The following is a description of a gene set: Genes predicted to be targets of miRBase v22 microRNA mmu_miR_5121 in miRDB v6.0 with MirTarget v4 prediction scores > 80 (high confidence targets). Mouse Gene Set: MIR_5121 studied in species Mus musculus from publication Chen Y, Wang X (PMID 31504780), and this is the list of marker genes: Apbb2, Mal, Lrrtm2, Foxp4, Cxcl14, Abhd14a, Nfia, Trp53inp1, Disp3 (dispatched RND transporter family member 3), Eno2, Dbndd1, Tmem150c, Gabarapl1, Adgrf2, Mtfr1, Senp1, Kmt5b, Arpp21, Fgf14, Jade2, Tmem144, Cpeb2, Dlx4 (distal-less homeobox 4), Farp1, F2rl1, Jdp2, Glce, Fat3, Rgs18, Moxd1, Neurod1, Zfp236, Zfp94, Kansl1l, Canx, Lrrtm4, Arnt2, Tram1, Nacc1, Stmn2, Adamts12, Nsd3, Zfhx4, Gorab, Tmed5, Mef2d, Tpx2